The following is a description of a gene set: Human Gene Set: GOBP_POST_TRANSLATIONAL_PROTEIN_MODIFICATION The process of covalently altering one or more amino acids in a protein after the protein has been completely translated and released from the ribosome. species: Homo sapiens, and this is the list of marker genes: HSPA5 (heat shock protein family A (Hsp70) member 5), MARCHF6, SPHK1, IFT80, LRSAM1, SYVN1, USP37, KLHL9 (NCBI Gene Id 55958), USP36, RFWD3, RELA, CUL5, FBXO38, USP40, PELI3, FOLH1B, RNF44, CUL4B, USP17L21, CTU1, PER2, MKRN3, ANKRD9, KLHL8, TRIM68, PSMD14, OTULIN, ASB9, TRIM11, PKN1, USP44, FBXO6, SENP8, MINAR1, DNAJA1, WSB1, USP45, LRRK2, TTC36, UBE2S, HSP90AB1, RNF217, UNKL, COPS7B, NXN, GABARAP, ZSWIM2, WDR48, MUL1, WWTR1, RAD18, NHLRC1, PINK1, UBR1, FBXO11, RNFT1, SPSB3, TRIM45, USP51, COPS2, PEX10, ZFP91, ZMIZ2, TRIM38, RNF126, TRIM33, RAB40AL, OTUD7A (NCBI Gene Id 161725), TNFAIP3, BIRC6, TRIM58, USP17L24, RNF169, USP17L6P, MAP3K12, ATG3, PPIL2, NOD2, MAGEA2B, ASB4, ASB17, TRIM8, OTULINL, PIAS4, DTL, KLHDC2, RNF186, COMMD1, RNF123, TTC3 (tetratricopeptide repeat domain 3), TNKS2, HERC2, SIRT6, TGFBR1, PRAMEF6, RBCK1, KLHL18, USP22 (ubiquitin specific peptidase 22), HERC2P3, WDR24, HSPA1A, SPSB1, CAMLG, MARCHF4, USPL1, FAM107A, USP48, FBXO10, RNF144B, VHL, CHFR, USP17L15, FBXO45, IRGM, RNF25, WDTC1, PARP16, OTUD5, FBXL21P, RNF139, KCTD9, DERL1 (derlin 1), MED7, SLF1, MKRN2 (NCBI Gene Id 29073), CUL2, ARK2C, RAB40B, FBXL3, KLHL25, RACK1, RPL11, BEX2, USP17L7, AKTIP, UBE4B, DCAF16, PINX1, CCNB1IP1, RNF130 (ring finger protein 130), UBA1, UBA3, UBB, FBXL17, DCUN1D4 (NCBI Gene Id 23142), ZNF738, DDX3X, PRPF19, UBR3, ANAPC2, PRAMEF9, KLHL42, TRIM9, BCL11A, HLCS, KLHL36, JOSD1, PPIA, UHRF1, SUMO4, UBE2W, KCTD10, ZNRF4, RPS3, TRIM52, UBE2E1, TRIM24, RNF125, TRIM23, TRIM5, SPSB4, ATG7, WWP1, FANCL, UBE2O, DESI1, AMER1, USP2, GMCL2, UBE2R2, MAD2L1, RASD2, P3H1, HECTD2, SUMO1P1, FOLH1, AMBRA1, DDB1, TMEM129, STX1A, FBXL5, UBE2D4, MGRN1, UBE3A, BFAR, MARCHF8, BIRC8, UBA52, NEURL3, ZRANB1, UBE2C, HDAC8, TNKS, USP43 (ubiquitin specific peptidase 43), USP47, DCAF1, HERC5, NDP, USP53, LCMT1, SMURF1, YOD1, ARNT, TRIM25, KLHL17 (kelch like family member 17), USP1, RNF122, RHBDD1, MEGF8, DSCC1, UBAC1, CENPX, CBLB, RNF157, TSPO, PCNP, CAPN3 (calpain 3), MARCHF3, USP10, SEPTIN4, ABCA2, PARP1, CBLL2, SUMO2, ASB11, UCHL3, PTPN22, RNF183, RANBP2, RNF216, HECTD3, PIAS3, HECTD4, UBQLN1, TCF25, TBC1D7, RNF149, RC3H2, RNF41, RNF114, ARRDC4, NOP53, ATXN3L, TULP4, CBLC, ARIH1, RNF19B, UBE2H, TRIM7, SAE1, SENP3, UBE2QL1, RNF225, WNK1, BAP1, KCMF1, USP18, SKP2, SOCS7, AREL1, APPBP2, BIRC7, USP5, RNF135 (ring finger protein 135), STAMBPL1, ANKIB1, RNF5, SMC6, SIRT2, HECTD1, UBE2M, HMG20A, COPS9, AURKB, PADI4, SOCS3, SENP5, ARRB1, STT3A, PARK7, RWDD3 (NCBI Gene Id 25950), MIR138-1, JOSD2, USP17L13, BAG5, USP16, AGTPBP1, PARP12, CTNNB1, HIF1A, MED17, COPS8, RAB40A, COPS4, DTX2, USP17L12, FBXO22, USP17L2, UBE2E3, USP25, GNL3L, FBXL22, THOP1, ANAPC7, TANK, CBLL1, ASB18, RNF115, RNF14, TRIM44, CDK5, SPRTN, USP34, CDC26, TRIM41, RNF182, RAB40C, TRIM28, ZSWIM8, HECW1, USP17L5, RC3H1, PLK1, MED8, TRIM4, USP19, KLHL7, RNF8, RNF220, KCTD11, DET1, RASSF5 (Ras association domain family member 5), STUB1, RPS27A, COP1, UBR2, HERC1, MED11, EIPR1, EID3, TRIM55, IFI27, LMO7, FANCM, NDFIP1, MED12, OTUD1, NEDD4, RAG1, SUMF1, BCL2, NHLRC3, EPM2A, KCTD21, ANAPC5, RASSF1 (NCBI Gene Id 11186), USP42, ANAPC10, UBOX5, COPS5, TRIM34, TRIM56, KBTBD13, COPS6, TPST1, NFE2L2 (NCBI Gene Id 4780), UBE2L5, USP39, TRAF7, RING1, DCAF17, IVNS1ABP, ICMT, TRIM71, ANAPC13, GPS1, RNF144A, TTL, GAN, RNF6, SMURF2 (NCBI Gene Id 64750), UBE2Z, USP30, ANAPC16, RPS6KA4, TAF1, RNF180, TRAF2, RNF121, FBXO9, SOCS6, NFATC2IP, FBXO3, COPS3, BAZ1B, TRIM63, KLHL21, KBTBD7, SHPRH, USP24, UFC1, RPS7, UBE2V1, ASB12, ABL1, CDC14B, TRPM4, NSMCE2, PHRF1, SKP1, VPS18, RNF187, FBXO31, DDB2, NPEPPS (NCBI Gene Id 9520), ATG5, USP7, PARP6, HINT1, MOCS3, USP20, PDCD6, PELI2, UBA7, USP29, PIAS2, KLHL20, U2AF2 (U2 small nuclear RNA auxiliary factor 2), UBXN1, VCPIP1, NEUROD2, FBXL12, CDCA3, PRKN, ASB8, OTUB2, LRR1, TRAF3IP2, USP50, CUL1, RMND5A, TRIM27, RNF228, PARP8, MYCBP2, RNF4, ASB13, ABRAXAS2, DTX4, ASB3, USP4, DCST1, ANGPT1, HECW2, AIMP2, PRICKLE1, ATG10, KCTD13 (NCBI Gene Id 253980), CUL7, ASB14, PEX2, MDM4, HUWE1, RPL5, OTUD4, SPOPL, UBR5, TRPC4AP, C10orf90, PEX12, USP17L22, SUMO1, BMI1, CDC23, TRIM22, GSK3A, BTRC, TOPORS, ZNRF1, NEURL2, FSCB, RNF10 (NCBI Gene Id 9921), MARCHF10, TRIM32, FZR1, RNF133, HMG20B, PJA2, HSPA1B, KBTBD6, ADGRB1, RNF112, RNF212, RNF20, USP12, INAVA, NSMCE4A, MTA1, FBXO43, RPGR, SENP1, G2E3, PIAS1 (protein inhibitor of activated STAT 1), RNF40, ZBTB16, TRIM40, UBR4 (ubiquitin protein ligase E3 component n-recognin 4), RNF38, RNF111, KLHL40, USP8, TRIM47, GTPBP4, ZBED1, UBE2J2, MAPK9, MYLIP, SIAH2, UBE2K, CDK1, CAV1 (caveolin 1), FBXW11, NEDD4L, USP27X, UBE2D3, USP32, AGBL4, PARP15, UBE3C, LTN1, RIPK2, DCUN1D1, UBE2D2, FBXW12, RBBP6, TRIM26, HDAC3, TRIM13, PABPN1L, FEM1C, CDKN2A, TRIM62, RNF39, UBE2E2 (ubiquitin conjugating enzyme E2 E2, NCBI Gene Id 7325), PARP3, RNF34, CYLD, USP3, USP17L10, LZTR1, FBXO30, ZC3HC1, ARRDC3, FBXL15, CEP63, RNF167, FN3K (fructosamine 3 kinase), RNF103, UBC, RPS6KA5, ZC3H12A, TRIM39, UBE2N, AGBL1, CDK5RAP3, ISG15 (NCBI Gene Id 9636), USP17L11, BRCA1, DCUN1D3, ZNRF3, RNF128, TRIM21, ANAPC15, FLCN, LARGE1, NEURL1B, TRIML1, RNF2, DCAF4, MKRN1, USP54, DCAF12, TRAF6, ABCB11, MDM2, NSMCE3, NMI, KLHDC3, SOCS1, SVBP, SENP6, DCAF8, LNX1, TRIP12, ATXN3 (ataxin 3), PCMTD1, PARP11, CDK2 (NCBI Gene Id 1017), PARP10, FBH1, KLHL13, SPRY2, RNF26 (NCBI Gene Id 79102), ELOB, USP33, SH3RF3, UBA2, RNF181, NAE1, CBL, FBXW5, MED10, MSL2, PSMD10, HDAC4, TOR1A, METAP1D, MAGEF1, CCNF, KLHL12, KLHDC1, FBXW8, SDE2, RNF185, BEX4, TRIM31, NAA50 (NCBI Gene Id 80218), ANAPC11, MED30, KLHL22, CRTAP, CDC20, CTU2, SENP7, HDAC7, FBXO33, PARP14, UBE2J1, KLHL41, PRKCG, SIRT7 (NCBI Gene Id 51547, sirtuin 7), LRRC41, DCAF6, OTUD7B, CCNA2, KCTD6, UBE3D, TSPYL5, HERC4, FBXL2, E4F1, UBE2B, USP6, BIRC3, RNF152, PRKCE, KLHL2, UBE2NL (NCBI Gene Id 389898), UFL1, MIB1, FEM1A, USP17L1, BEX3, MAGEC2, VPS11, CRY1, PRKCD, SHMT2, CISH, EGR2, FBXO24, MARCHF9, FBXO25, WWP2, PEF1, RNF170, TRIM59, CCAR1, KLHL10, NPM1, NUB1, BIRC2, USP17L8, BARD1, USP17L3, FBXO5, USP15, DTX1, CHP1, SMC5, SH3RF1, MIB2, TRIM65, OTUD6B, USP17L19, MARCHF7, FANCI, KBTBD8 (kelch repeat and BTB domain containing 8), CUL9, FBXL7, TNIP1, RNF212B, UBA6, UBE4A, AKT1, ATG16L1, MAGEA2, URM1, USP17L23, GSK3B, RNF43, MID2, RNF213, DDA1, WBP1L, UBE2A, FBXW7, CEP78, RNF11, UBE2G2, MALT1, TRIB3, ARRDC1, ZNF451, USP46, CDC16, ELOC, UHRF2, DCAF10, KIAA1586, BRAP, USP17L18, USP49, UBXN2A, MINDY4B, PDF, KLHL3, MAGEL2, MED31, RFFL, SUMO3, NSMCE1, EGR1, RNF208, MAD2L2, CNOT4, ZC4H2, UCHL5, ASB6, KLHL15, SIRT1, IRF2BP1, DCAF11, TRIM42, FYN, PJA1, ZMIZ1, UBR7, RNF146, PRAME, TRIM2, RNF13, ARIH2, UBE2L6, USP35, BCL10, CAND1, FBXO28 (NCBI Gene Id 23219), DAXX, KLHDC10, TRAIP, DCAF7, KLHL24, KDM1A, ESCO2, DCAF13, UBE2F, HERC6, PDZRN3, ITCH, USP9X, ANAPC4, TNFAIP1, MINDY4, UVSSA, ASB7, RNF138, FAM20C, MARCHF5, RBX1, HDAC6, RNF19A, FEM1B, SPATA2, BTBD1, SIAH1, HERPUD1, WDR77, CUL3, NEURL1, ANAPC1, ASB2, UBA5, KDF1, DAW1, NFE2L1, USP17L17, PLAA, UBE2L3, ENC1 (ectodermal-neural cortex 1), FREY1, FBXO7, UFSP1, USP9Y, SENP2, SOCS2, SHARPIN, SPSB2, TPP2, COPS7A, TRIM35, AXIN1, RPL23, FOXF2, BLMH (bleomycin hydrolase), NEDD8, USP38, NDFIP2, RPS2, DTX3, TRIM37, DZIP3 (NCBI Gene Id 9666), SOCS4, ASB5, ERCC8, HAMP, MARCHF11, STT3B (STT3 oligosaccharyltransferase complex catalytic subunit B), SQSTM1, OBI1, UBE2Q1, CAND2, UBE2Q2, VPS28, VCP, USP14, ZNF598, STAMBP, BAG2, OTUB1, MED27, PTTG1IP, DDRGK1 (NCBI Gene Id 65992), MINDY3, TRIML2, HSPBP1, LAPTM5, MED21, SLF2, N4BP1 (NEDD4 binding protein 1), NQO1, RLIM, DCAF5, PPP1R11, ARRB2, MED6, SASH1, UCHL1, TRIM17, PARP2, HSP90AA1, FN3KRP, GCLC, OS9, USP21 (NCBI Gene Id 51558), FBXO4, MARCHF1, ASB16, PARP9, DTX3L (deltex E3 ubiquitin ligase 3L), GNL3, RNF166, RNF113A, KBTBD2, TICAM1, RNF31, NGF, WDSUB1, PAXIP1, CDC34, CDC27, FAU, HERC3, USP31, USP11, XIAP, LNPEP, PELI1, UBE2T (NCBI Gene Id 29089), FBXO32, ASB15, BEX1, USP28, CRBN, USP13, ASB1, RNF141 (ring finger protein 141), TOLLIP, EPAS1, DCUN1D2, NFX1, AGBL5, RNF223, USP17L20, RCHY1, CENPS, ASB10, ZNRF2, WFS1, HACE1, PHF23, DNAJB2, DCAF15, SOCS5 (NCBI Gene Id 9655), BABAM2, UBE2U (NCBI Gene Id 148581, ubiquitin conjugating enzyme E2 U), TRIM3, WSB2, PML, MARCHF2, IRF2BPL, SPOP, RNF168, GPS2, CUL4A, TRIM69, UBE2D1, ESCO1, CBX4, IFIH1, NBN, BRCC3, MARCHF6-DT, CBFB, OGT, USP17L4, RNF7, UFM1, JAK2, MIR101-1 (NCBI Gene Id 406893), FBXO2, MTBP, OTUD6A (OTU deubiquitinase 6A), HLTF, DCUN1D5, RNF227 (NCBI Gene Id 284023), DNAJA3, UBE2G1, PRMT3, UBE2V2, WASHC1, UBE3B, MED1, NT5C2, AMFR, OTUD3, VIPAS39 (VPS33B interacting protein, apical-basolateral polarity regulator, spe-39 homolog), UBD, KEAP1, SH3RF2, RUSC1 (NCBI Gene Id 23623), USP26, ZC3HAV1, EYA1, JADE2, TRIM6, UBE2I, RANGAP1, PPIB